Given this list of marker genes TLR4, SLC15A3, BIRC3, ERBIN, SLC15A2, HSPA1B, SLC46A2, ZNRF4, BIRC2, SLC15A4, XIAP, HSPA1A, PTPN22, NAGK, TNFAIP3, here is a description of the gene set: species: Homo sapiens Human Gene Set: GOBP_REGULATION_OF_NUCLEOTIDE_BINDING_DOMAIN_LEUCINE_RICH_REPEAT_CONTAINING_RECEPTOR_SIGNALING_PATHWAY Any process that modulates the frequency, rate, or extent of a nucleotide-binding domain, leucine rich repeat containing receptor signaling pathway (NLR) pathway.